The following is a description of a gene set: species: Homo sapiens Human Gene Set: GOBP_REGULATION_OF_CATECHOLAMINE_UPTAKE_INVOLVED_IN_SYNAPTIC_TRANSMISSION Any process that modulates the frequency, rate or extent of the directed movement of catecholamine neurotransmitters into a neuron or glial cell., and this is the list of marker genes: DRD4, TOR1A, SNCA, DRD1, GDNF, RAB3B, DRD2, DRD3